The following is a description of a gene set: MTOR signalling studied in species Homo sapiens Human Gene Set: REACTOME_MTOR_SIGNALLING, and this is the list of marker genes: PRKAB2, PRKAA2, RRAGB, SLC38A9, RPS6KB1, PPM1A (protein phosphatase, Mg2+/Mn2+ dependent 1A), TSC2, TSC1, AKT1, PRKAG1, EIF4E, MTOR, EIF4B (NCBI Gene Id 55378), CAB39L, EEF2K, PRKAB1, STRADA, STRADB, RHEB, RRAGC, LAMTOR3, STK11, PRKAA1, LAMTOR1, RPTOR, FKBP1A, LAMTOR4, AKT1S1, MLST8, RPS6, AKT2, CAB39, RRAGD, RRAGA, LAMTOR5, YWHAB, EIF4G1, EIF4EBP1, PRKAG2, LAMTOR2, PRKAG3